Given this list of marker genes GFRA1, ROBO1, UBAP2L (ubiquitin associated protein 2 like), FGF20, TCTN2, ITGA8 (NCBI Gene Id 8516), here is a description of the gene set: species: Homo sapiens A complete or near-complete lack of amniotic fluid surrounding a fetus. This finding can be observed sonographically in the third trimesters if the deepest pocket of amniotic fluid is less than or equal to 2 cm. Human Gene Set: HP_ANHYDRAMNIOS Anhydramnios